Given this list of marker genes FUZ, NODAL, HAAO, FANCB, CCL2, ZIC3, VANGL2, TBXT, MNX1, PTH1R, VANGL1, here is a description of the gene set: Human Gene Set: HP_ABSENCE_OF_THE_SACRUM studied in species Homo sapiens Absence (aplasia) of the sacrum. Absence of the sacrum